Given this list of marker genes PPP1R16B, KDR, PGAM2, JAG2, TM4SF1, ACE, TXNIP, PECAM1, GLCE (glucuronic acid epimerase), CABLES1 (NCBI Gene Id 91768), EPAS1, FHL2, HDAC2, PALMD, ITGA6, ANXA1, ZNF521, BGN, ARL5A, SASH1, CCNA1, MYOF, LDB2, C1orf43, RPS3A, UQCR10, CTNNAL1, IGFBP4, GASK1B, NQO1, RGS4, THSD7A, ATP5F1A, BMX, CAPNS1, CDCA7L, CAVIN2, ARHGDIB, HTR1B, PDLIM4, MTUS1, RHOJ, DDR1, CCN2 (NCBI Gene Id 1490), PCTP, ARL6IP1, NFIB, ANTXR1, POSTN, EFEMP1, AHNAK2, KRT7, ZBTB47, SRSF7, EMCN, PHLDA1, GIMAP6, NT5E, CRIP2, TGM2, GBA2, LYVE1, CLU, CALCRL, MMRN1 (multimerin 1), DNAJB4, CD34, NOS3 (nitric oxide synthase 3), SMYD2, KCTD12, ATP1B3, HERC2P2, ITPRID2, ALDH1A1, TMSB4X, GIMAP7, TXNDC5 (thioredoxin domain containing 5), VWF, PRKACB, PRKCH, APLN, CDK2AP1, NTN4, TPT1, DHRS11 (dehydrogenase/reductase 11), here is a description of the gene set: species: Homo sapiens Human Gene Set: SANA_TNF_SIGNALING_DN To investigate the potential molecular mediators of tissue-specific recruitment, we explored the influence of different cytokine challenges on gene expression regulation in five primary endothelial cells (ECs), representing two different phenotypes: iliac artery and aortic (macrovascular); lung, colon and dermal (microvascular). We challenged ECs with cytokines that elicit different patterns of inflammatory and immune responses in immune cells: tumor necrosis factor (TNF-alpha), interferon-gamma (IFN-gamma) or interleukin-4 (IL-4), and used microarrays containing approximately 40,000 unique cDNAs, to assess changes in differential gene expression relative to untreated cells. Five hundred and sixty three sequences changed by at least 2.5 fold in one or more of the 15 possible EC /cytokine combinations. The list included highly regulated adhesion molecules, chemokines, cytokines, metalloproteases, and IFN-gamma-induced genes. Overall, IFN-gamma caused the largest number of gene expression changes and its profile was least correlated with IL-4. In addition to clusters that were predominantly EC/cytokine specific, we also observed several clusters that were regulated by more than one cytokine across several ECs. Furthermore, we identified genes that were reciprocally expressed in response to different cytokines that could serve as markers of inflammatory and immune expression. These results confirm the importance of microenvironment in primary ECs that could have important applications in developing targeted therapies for vascular diseases. from publication Sana TR, Janatpour MJ, Sathe M, McEvoy LM, McClanahan TK (PMID 15749026) Genes down-regulated in five primary endothelial cell types (lung, aortic, iliac, dermal, and colon) by TNF.